The following is a description of a gene set: Mouse Gene Set: PILON_KLF1_TARGETS_UP Genes up-regulated in erythroid progenitor cells from fetal livers of E13.5 embryos with KLF1 knockout compared to those from the wild type embryos. from publication Pilon AM, Arcasoy MO, Dressman HK, Vayda SE, Maksimova YD, Sangerman JI, Gallagher PG, Bodine DM (PMID 18852285) Erythroid Krüppel-like factor (EKLF) is a Krüppel-like transcription factor identified as a transcriptional activator and chromatin modifier in erythroid cells. EKLF-deficient (Eklf(-/-)) mice die at day 14.5 of gestation from severe anemia. In this study, we demonstrate that early progenitor cells fail to undergo terminal erythroid differentiation in Eklf(-/-) embryos. To discover potential EKLF target genes responsible for the failure of erythropoiesis, transcriptional profiling was performed with RNA from wild-type and Eklf(-/-) early erythroid progenitor cells. These analyses identified significant perturbation of a network of genes involved in cell cycle regulation, with the critical regulator of the cell cycle, E2f2, at a hub. E2f2 mRNA and protein levels were markedly decreased in Eklf(-/-) early erythroid progenitor cells, which showed a delay in the G(1)-to-S-phase transition. Chromatin immunoprecipitation analysis demonstrated EKLF occupancy at the proximal E2f2 promoter in vivo. Consistent with the role of EKLF as a chromatin modifier, EKLF binding sites in the E2f2 promoter were located in a region of EKLF-dependent DNase I sensitivity in early erythroid progenitor cells. We propose a model in which EKLF-dependent activation and modification of the E2f2 locus is required for cell cycle progression preceding terminal erythroid differentiation. studied in species Mus musculus, and this is the list of marker genes: Ola1, Me1 (malic enzyme 1, NADP(+)-dependent, cytosolic), Cyld, Mllt3, Ddhd2, Trmt10a, Mdm2, Fech, Hs3st3b1, Dnaja4, Snca, Ankrd39, Slc38a4, Apoa2, Plg, Csnk1g1, Slc36a2, Garre1, C1qa, Ftsj1, Cdsn, Dennd2c, Mis18bp1 (NCBI Gene Id 97807), Hc, Sbno1, Ank3, Aopep, Hars2, Pir (NCBI Gene Id 69656), Camk2n1, Dcn, Pbx1, Atp5if1, Slc39a5, Timp3, Eif5a2, Ccnt1 (cyclin T1), Flt1, Tmem158, Tgfbr3, Nlk, Rhoc, Flt4, Magt1, Zfp266, Slamf1, Ralgapb, Igfbp2, Insr, Scai, Trf, Spats2l, Itsn1, Ric1 (RAB6A GEF complex partner 1), Ascc2, Tent5c, C1s1, Ambp, Cfb, Ednrb, Pitrm1, Cald1, Kif2a, Lgr6, Fermt2, Abcc3, H1f4, Tent2, Eps15, Nup54, Gnl3l, Cttn, Arhgap29, Napg, Car1, Pmm2, Agfg1, Rhbdf1, Mpzl2, Vtn, Itm2a, Ttc39a, Pkd2, Slc30a10, Igfbp1, Nsfl1c, Alox12, Hipk2, F2, Gypa, Cited4, Col18a1, Hectd1, Loxl2 (NCBI Gene Id 94352), Clk2, Loxl4, Rbp4, Gpc3, Armc1, Clasp2, Cdh2, Sin3a, Ndrg2, Mthfd2, Igfbp7, Cxadr, Gmps (NCBI Gene Id 229363), Exog, Pon2, Tial1, Prss53, Ghr, Gata6, Apoa1, Hspa9, Col1a2, Serpinf2, Fbxo9, Rnf168, Gpc6, Dennd2b, Rnf20, Aebp1, Ptprb, Dcbld2, Herc4, Arxes1, Wdr43, Itih1, Il1b, Emsy, Spta1, Tead1, Fbn2, Crb3, Maged1 (NCBI Gene Id 94275), Asph, Nr1h3, Vopp1, C2cd3, Amot, Obsl1, Hars1, Foxh1, Igsf1, Rad18, Lipg, Podxl, Epb42, Rars1, Dnm1l, Kif26b, ENSMUSG00000128398, Abcc9, Slc6a8, Serpinh1, Luc7l2, 2810459M11Rik, Dlk1, Mesp1, Col4a1, Itih2, Srsf5, Hbb-bh1, Pigm, Dll1, Itga2b, Serpina10, Pzp, Clca3a1, Kpna1, Pkdcc, Vwf, Tmc7, Eif2ak1, 1700028E10Rik, Slc39a8, Hbb-y, Osgepl1, Myl9, Slc22a23, Apoh, Mzt1, Fryl, Pum2, Osbpl1a, Tmem150a, Gm4022, Exd1 (exonuclease 3'-5' domain containing 1), Bnip3, Nudcd1, Cyp2c40, Sntb1, Fzd1, Prrg3 (proline rich Gla (G-carboxyglutamic acid) 3 (transmembrane)), Hpx, Lpl, Col11a1, Slc23a2, Dram2, Klhl20, Kng1, Gc, Nt5c3, Ppp6r3, Fgb, Chd8, Sdc2, Ube2o, Septin2, Gm33111, Myh7b, Trim10, Ogfrl1, Gtf2h2, Asxl2, H2-Q10, Rbm5, Akr1b8, Igsf3, Fgg, Cwc25, Tbxas1 (NCBI Gene Id 21391), Bpgm, Mrpl47, Usp8, Igtp, Irag1, Meg3, Tmem59l (transmembrane protein 59-like), Zfand5, Slc25a4 (solute carrier family 25 (mitochondrial carrier, adenine nucleotide translocator), member 4), Xpo4, Itih3, Col3a1, Arih1, Tlcd4, Gm20161, Tada2b, Deptor, Stab2 (stabilin 2), Tmem30a, Xpr1, Reps2, Gins3 (GINS complex subunit 3), Islr (NCBI Gene Id 26968), Abca8b, Fga, Tmem132d, Mt1, Septin4, Tceal9, Ttr, Slc44a2, Asap1, Abcg2, Pls1, Ctnnal1, Kmt5b, Crp, Ccdc92b, Amotl1, Abcc8, Gclm (NCBI Gene Id 99692), Mylk, A730091E23Rik, Pmp22, Smim15, Cpsf2, Pxdn, Nrp2, Dusp8, Rabgap1, Dnajc22, Shoc2, Bgn, Rian, Ypel4, Cgn, Ppox, Foxp2 (NCBI Gene Id 72715), Cyp2d22, Afm, Airn, Zfp639, Ppbp, Marco, Magel2, Mboat2, Col6a2, Irs2, Ell2, Fgfr2, Lhfpl6, Serpinc1, Aldoc, Larp4b (NCBI Gene Id 442810), Chac2, Ap5s1, Actb, Ptprd, Prkar2b, Gm36307, Zfp239, Fabp4, Aadac, Dnajb4, Enox2, Haus1, Csnk1a1, C2cd2, Masp1, Asb1, Vcam1, Fbxo46, Med13, Xk, Apob, Peg3, Tspan9, Slc44a1, Kntc1, Zswim7, Sgms1, Fam114a1, Dmpk, Dusp9, Top2a (NCBI Gene Id 21973), 5330426L24Rik, Ryk, Sema4g, Zfp352, Grb10, N4bp2, Serping1, Rnf157 (NCBI Gene Id 69919), Picalm, 4930572G02Rik, Srek1ip1, Krt8, Pan3, Rab36, Bfar, Oga, Rnf128, Ptar1, Col14a1, Kmt2a, Kif3b, Slbp, Igf2 (insulin-like growth factor 2), Ctse, Bcar1, Abca1, Trip4, Ccnc, Serpina6, Epb41l5, Col1a1, Ak4, Cap2 (cyclase associated actin cytoskeleton regulatory protein 2), Mios, Cep76, Fstl1, Hycc1, Zfp207, Tuft1, Cpeb4, Pcsk7, Acox2, Slc27a2, Rbp1, Crx, Itga4, Bola2, Ahsg, Alcam, Tmem9, Mib1, Ppfia1, Hmgcs1, Rrp1b, Mlxipl, Supt16, Zfp493, Hnf4a, Fzd5, Cdh5, Treml4, Ank, Msr1, Hpn, Hmox1, Rbms1, Sv2b, Snx14, Malat1, Aftph, Btn1a1, Rec114, Dhx57, Tlk1, Sugp2, Ing4, Cx3cl1, Hmg20a, Tnks2, Pign, Prkar2a, Cd59a, Huwe1, Lpin2, Fkbp10, Resf1, Ralbp1, Ptprf, Hsd3b2, Ptdss2, Fn1, AI597479, Clcn3, Atp1b2, Sema5b, Sh3yl1, Apom, Ttc39aos1, Plxna2, Zfr, Etnk1, Dab2, Alas2, Mkrn1, Clu, Gas2l1 (NCBI Gene Id 78926), Rab6a (RAB6A, member RAS oncogene family), Acsl4 (NCBI Gene Id 50790), Hgfac, 3110040M04Rik (RIKEN cDNA 3110040M04 gene), Mier1, Angptl3, Afp, Spp2, Cop1, Gng11, Lect2, C1galt1, Dnajb2, Pla1a (phospholipase A1 member A), Bmp2k, Wwc1, Ston2, Mirg, Tbk1, Eloc, Ttll5, Gigyf2, Per3, Foxo3, Lum, Mbnl1, Exoc6, Sparc, Gpx5, Plek2, Mfsd2b, Esam, Igf1r, Prss40, Wdr37, Ihh, Cfi, Tspan7, C8g, Ntmt1, Nid2, Ebp, Cavin2, Wnt11, Gtf2ird2, Zbtb45, Dlc1, Gucy1a1, Hibch (3-hydroxyisobutyryl-Coenzyme A hydrolase), Alb, Col2a1, Trio, Daam1, Ndn, Wdr19, Rps6ka3, Setdb1, Plagl1, Ptger3, Nap1l1, Dlat, Arfgap2, Nrk, Col5a2, Sema6d, Tbx6, Mlph, Srxn1, Agrn, Ciapin1, Fcna, Kel, Lpp, Adam12, Slc30a1, A2m (NCBI Gene Id 232345), Dcaf1, Agmat, Cela1, Ugt2b34, Tango2